The following is a description of a gene set: The exact role of SHC1 in FGFR signaling remains unclear. Numerous studies have shown that the p46 and p52 isoforms of SHC1 are phosphorylated in response to FGF stimulation, but direct interaction with the receptor has not been demonstrated. Co-precipitation of p46 and p52 with the FGFR2 IIIc receptor has been reported, but this interaction is thought to be indirect, possibly mediated by SRC. Consistent with this, co-precipitation of SHC1 and FGFR1 IIIc is seen in mammalian cells expressing v-SRC. The p66 isoform of SHC1 has also been co-precipitated with FGFR3, but this occurs independently of receptor stimulation, and the p66 isoform not been shown to undergo FGF-dependent phosphorylation. SHC1 has been shown to associate with GRB2 and SOS1 in response to FGF stimulation, suggesting that the recruitment of SHC1 may contribute to activation of the MAPK cascade downstream of FGFR. studied in species Homo sapiens part of: Downstream signaling of activated FGFR2 Reactome Pathway: SHC-mediated cascade:FGFR2, and this is the list of marker genes: FGF18, SOS1, FGF10, FGF3, FGF5 (fibroblast growth factor 5), FGF17, GRB2, SHC1, FGF8, FGF20, FGF16, FGF1, FGF9, FGF6 (fibroblast growth factor 6), FGF7, NRAS, FGFR2, FGF2, FGF23, FGF22, KRAS, FGF4, HRAS (HRas proto-oncogene, GTPase)